Given this list of marker genes Kmt2a, H3c6, Ash2l, H4c11, H3c15, Dot1l, H3c4, Atf7ip, H4c6, Setd3, Rbbp5, Rela, H4c14, Ehmt1, H4c3, Kmt5b, Ehmt2 (euchromatic histone lysine N-methyltransferase 2), Setd7, H4c17, Setdb1, Smyd2, Kmt2b, H3c3, H3c7, Setd6, Nsd2, H4c4, Prdm16, H3c13, H3c8, Setdb2, Kmt5a, H4c8, Ash1l, Aebp2, H3c11, H4c16, Kmt5c, H3c1, Prdm9, Suv39h1, Rbbp4, Nsd1, Nfkb2, Nfkb1, Kmt2d, H4c1, Setd1b (NCBI Gene Id 665515), H3c14, Rbbp7, H3c2, Nsd3, Wdr5, Setd2, Eed, H4c18, Smyd3, Ezh2, H4c9, H4c2, H4c12, Suv39h2, H3c10, Suz12, Setd1a, here is a description of the gene set: PKMTs methylate histone lysines studied in species Mus musculus Mouse Gene Set: REACTOME_PKMTS_METHYLATE_HISTONE_LYSINES